The following is a description of a gene set: Any process that stops, prevents or reduces the frequency, rate or extent of long-term synaptic potentiation. studied in species Homo sapiens Human Gene Set: GOBP_NEGATIVE_REGULATION_OF_LONG_TERM_SYNAPTIC_POTENTIATION, and this is the list of marker genes: EPHA4, C22orf39, TYROBP, ADORA1, ABL1, APP, FXR1, FAM107A, PTN, MIR30B, AGER, PRNP, APOE